The following is a description of a gene set: species: Homo sapiens Human Gene Set: WP_MFAP5MEDIATED_OVARIAN_CANCER_CELL_MOTILITY_AND_INVASIVENESS MFAP5-mediated ovarian cancer cell motility and invasiveness, and this is the list of marker genes: PTK2, TNNC1, PLCG1, JUN, MAPK1, MAPK3, CREB1, ITGB3, ITPR3, MFAP5, RYR3, PRKCQ, ITGAV